Given this list of marker genes CASP6, CASP8, SPTAN1, TJP1, LMNA, SATB1, BCAP31, PKP1, GSN, CDH1, FNTA, OCLN, PRKCD, DSP, DBNL, PTK2, ADD1, MAPT, PLEC, GAS2, DSG1, CLSPN (claspin), DSG3, DSG2, APC (APC regulator of WNT signaling pathway), VIM, CASP7, STK24, TJP2, BIRC2, STK26, PRKCQ, LMNB1, ACIN1, BMX, CASP3, ROCK1, CTNNB1, here is a description of the gene set: studied in species Homo sapiens Human Gene Set: REACTOME_APOPTOTIC_CLEAVAGE_OF_CELLULAR_PROTEINS Apoptotic cleavage of cellular proteins